The following is a description of a gene set: Human Gene Set: REACTOME_CREB1_PHOSPHORYLATION_THROUGH_THE_ACTIVATION_OF_ADENYLATE_CYCLASE studied in species Homo sapiens CREB1 phosphorylation through the activation of Adenylate Cyclase, and this is the list of marker genes: CALM1, PRKAR2B, PRKAR2A, PRKACA, ADCY8, ADCY1, PRKX, PRKAR1B, CREB1, PRKAR1A, PRKACB, PRKACG